Given this list of marker genes Hk1, Pmm2, Guk1, Mpi, Gmds, Gmppb, Dpm1, Gfus, Slc35c1, Gmppa, Pmm1, here is a description of the gene set: Mouse Gene Set: GOBP_GDP_MANNOSE_METABOLIC_PROCESS The chemical reactions and pathways involving GDP-mannose, a substance composed of mannose in glycosidic linkage with guanosine diphosphate. species: Mus musculus